The following is a description of a gene set: Any process that modulates the frequency, rate or extent of neutrophil migration. Human Gene Set: GOBP_REGULATION_OF_NEUTROPHIL_MIGRATION studied in species Homo sapiens, and this is the list of marker genes: CCR7, MIR223, LBP, SELENOK, MPP1, JAM3, MOSPD2, DPP4, FUT7, C5AR1, CD74, IL23A, THBS4, DNM1L, XCL1, CD99, FUT4, RAC1, CXCL8, SLIT2, CCL19, EDN1, PERP (NCBI Gene Id 64065), CCL21, RIPOR2, CAMK1D, CD99L2, IL1R1, TNFAIP6, DAPK2, MCU, C1QBP, TIRAP, BST1, MYD88, ADAM8, XG, MDK, NCKAP1L, C5AR2, C3AR1, RAC3, RAC2, RTN4, SLAMF8